The following is a description of a gene set: Mouse Gene Set: GOCC_BRUSH_BORDER_MEMBRANE studied in species Mus musculus The portion of the plasma membrane surrounding the brush border., and this is the list of marker genes: Slc7a9, Slc34a2, Slc20a2, Slc27a4, Gna13, Drd5, Atp6v0a4, Plb1, Ptger3, Slc11a2, Mttp, Slc26a3, Shank2, Rapgef3, Slc22a12, Aqp7, Slc26a6, Hsp90ab1, Slc6a14, Slc46a1, Slc6a20b, Slc5a8, Abcg2, Cltrn, Lrp2, Slc22a5, Cdhr2, Atp7a, Slc5a6, Folr1, Pex19, Hsp90aa1, Cybrd1, Lima1, Cubn, Ace2, Abcc2, Slc17a4 (solute carrier family 17 (sodium phosphate), member 4), Slc9a3, B4galt1, Pemt, Slc26a4, Amn, Slc7a11, Nherf1, Car4, Slc19a1, Slc34a3, Slco1a5 (NCBI Gene Id 28245), Slc5a1, Slc2a2, Pik3cb, Pth1r, Slc28a3, Cdhr5, Itln1, Gna12, Pcmt1, Trpm6, Anpep, Pdzk1, Mfsd10, Atp8b1 (NCBI Gene Id 54670), Npc1l1, Prkcb, Kcnk1, Slc5a2, Cd36, Slc34a1, Aqp1 (NCBI Gene Id 11826), Slc28a1, Enpep, Slc3a1, Aqp8, Abcb1a, Slc28a2, Pld2, Slc6a18, Abcg3, Slc6a19, Slc22a21, Ace